The following is a description of a gene set: Human Gene Set: GSE9988_LPS_VS_LPS_AND_ANTI_TREM1_MONOCYTE_DN from publication Dower K, Ellis DK, Saraf K, Jelinsky SA, Lin LL (PMID 18292579) species: Homo sapiens Genes down-regulated in comparison of monocytes treated with 5000 ng/ml LPS (TLR4 agonist) versus monocytes treated with anti-TREM1. TREM-1 is an orphan immunoreceptor expressed on monocytes, macrophages, and neutrophils. TREM-1 associates with and signals via the adapter protein DAP12/TYROBP, which contains an immunoreceptor tyrosine-based activation motif (ITAM). TREM-1 activation by receptor cross-linking is pro-inflammatory, and can amplify cellular responses to Toll-like receptor (TLR) ligands such as bacterial lipopolysaccharide (LPS). To investigate the cellular consequences of TREM-1 activation, we have characterized global gene expression changes in human monocytes in response to TREM-1 cross-linking in comparison to and combined with LPS. Both TREM-1 activation and LPS up-regulate chemokines, cytokines, matrix metalloproteases, and PTGS/COX2, consistent with a core inflammatory response. However, other immunomodulatory factors are selectively induced, including SPP1 and CSF1 (i.e., M-CSF) by TREM-1 activation and IL-23 and CSF3 (i.e., G-CSF) by LPS. Additionally, cross-talk between TREM-1 activation and LPS occurs on multiple levels. While synergy in GM-CSF protein production is reflected in commensurate mRNA abundance, comparable synergy in IL-1b protein production is not. TREM-1 activation also attenuates the induction of some LPS target genes, including those that encode IL-12 cytokine family subunits. Whereas positive TREM-1 outputs are abolished by the PI3K inhibitor wortmannin, this attenuation is largely PI3K-independent. These experiments provide a detailed analysis of the cellular consequences of TREM-1 activation, and highlight some of the complexity in signal integration between ITAM- and TLR-mediated signaling., and this is the list of marker genes: CD68, PISD, RLF, UPP1, LONP1, CALU (calumenin), TBC1D7, KLHL6, ATP6V1H, MIR23AHG, MOB1B, PLEKHM2, OGT, BAG3, GPCPD1, SPINK1, PIP4P1, SLC9B2, HAVCR2, CCR1, NEU1, SNX9, SNAPC1, ANKRD28 (ankyrin repeat domain 28), TXN, ZBTB21, MAPK13, CTSL, DYRK3, TRIB1, RHEB, TUT7, STX3, NR4A2, LY9, ATF3, GNPDA1, DTL, STX4, RNASEK, KLHL21, TMEM65, TPCN2, TLNRD1, MMP1, RRAGC, VMP1, CKS2 (CDC28 protein kinase regulatory subunit 2), TCEAL3, RB1CC1, AGAP3, SIGLEC15, ACSL3, LINC-PINT, SH3BP5, CRTAM, IL36RN, TEX10, RRN3P3, TMEM181, NRIP3, DAB2, FKBP15, TSC22D1, LBH, ACVR1, PLEKHO1, GLA, SPP1, S1PR3, SNUPN, ADCK2, SYN2, NEDD4L, DPH5, ZBTB43, GFOD1, CAMSAP1, FAM83G, ZMIZ1-AS1, LBX2-AS1, CRY1, PLCXD1, TNFSF14, TNFSF15, SLC19A2, NUDT4, SERPINE1, COL15A1, LONRF3, RGS1, ITPR1, ANKS6, SPRY2, OLIG2, ST18 (ST18 C2H2C-type zinc finger transcription factor), SLC3A2, GTF2A1, PRKAG2, MRGBP, TLR5, HES4, ATP6V1D, PLPP3, BCAR3, CORO1C, RHOBTB3, DDIT3, MMP19, ITGAX, RRAGD, THAP4, DCUN1D4, RRAD, LYSET, NRBP1, UBR7, RABGEF1, SPAG5, TNFRSF12A, GEM, NRROS, PPFIA1, NRARP, FAM131A (family with sequence similarity 131 member A), VPS37B, PHF13, ANKRD10, SOWAHC, PLEKHM1, SLCO4A1, ADCY3, ASPH, SGK1, RNF19A, FBXL5, FNIP2, NPC1, AKIRIN2, SCARB2, GCNA, MAP4K3, ST3GAL6, CDC42EP3 (CDC42 effector protein 3), EIF2AK3, TCEAL9, CEBPB, CD84, MIR21, MMP10, ZBTB2, DYNLT2B, RHOB, SMIM13, ZSCAN5A (zinc finger and SCAN domain containing 5A), MELTF, NAA50, LHFPL2, ACOX3, LRFN4, KCTD7, LPL, BHLHE40, SH3D21, TBC1D2, DCSTAMP, PPARG, BANP, ZC3HC1 (NCBI Gene Id 51530), GPALPP1, TDRD9, PTPRE, MOAP1, BRI3, CSF1, CSTB, SNX33, COPRS, FOSL1, MAFK, ATP6V1B2, STARD8, SCG5 (secretogranin V), GNA13, SDSL, CAMTA2, TMEM38B, CNST, EDN1, ZNF674-AS1, SERTAD2, SOS1, MIR22HG, LINC00856, RIOX1